Given this list of marker genes CD84, RABGEF1, IL13RA2, CD300A (NCBI Gene Id 11314), LGALS9, FOXF1, here is a description of the gene set: studied in species Homo sapiens Human Gene Set: GOBP_NEGATIVE_REGULATION_OF_MAST_CELL_DEGRANULATION Any process that stops, prevents, or reduces the rate of mast cell degranulation.